The following is a description of a gene set: species: Mus musculus from publication Cui A, Huang T, Li S, Ma A, Pérez JL, Sander C, Keskin DB, Wu CJ, Fraenkel E, Hacohen N (PMID 38057668) Genes negatively differentially expressed in cell type: CD8+ T cell upon treatment with cytokine: IL-13 in mouse lymph nodes in vivo. Mouse Gene Set: CUI_T_CELL_CD8_IL13_RESPONSE_DN Cytokines mediate cell-cell communication in the immune system and represent important therapeutic targets. A myriad of studies have highlighted their central role in immune function, yet we lack a global view of the cellular responses of each immune cell type to each cytokine. To address this gap, the authors created the Immune Dictionary, a compendium of single-cell transcriptomic profiles of more than 17 immune cell types in response to each of 86 cytokines (>1,400 cytokine-cell type combinations) in mouse lymph nodes in vivo. A cytokine-centric view of the dictionary revealed that most cytokines induce highly cell-type-specific responses. For example, the inflammatory cytokine interleukin-1β induces distinct gene programmes in almost every cell type. A cell-type-centric view of the dictionary identified more than 66 cytokine-driven cellular polarization states across immune cell types, including previously uncharacterized states such as an interleukin-18-induced polyfunctional natural killer cell state., and this is the list of marker genes: Uba52, Hspa1a, Hspa1b, Klf6, Fos